The following is a description of a gene set: species: Homo sapiens Human Gene Set: GOBP_REGULATION_OF_SKELETAL_MUSCLE_CONTRACTION_BY_CALCIUM_ION_SIGNALING Any process that modulates the frequency, rate or extent of skeletal muscle contraction by changing the calcium ion signals that trigger contraction., and this is the list of marker genes: GSTO1, DMD, DMPK, FKBP1A, GSTM2, CASQ1, PRKD1, REM1